Given this list of marker genes PROM1, RLBP1, AIPL1, AHI1, PDE6A, ARL6, FBLN5, CFHR3, CFAP418, IMPDH1, PRPF6, CERKL, ABCA4, CFH, MFRP, ZNF408, ZNF513, RPGR, BBS2, IFT172, NRL (NCBI Gene Id 4901), KIZ, ALMS1, PRPH2, DHDDS, PRPF8, CC2D2A, EYS, GUCA1B, GDF6, SPATA7, KLHL7, FAM161A, IFT88, TOPORS, CRB1, SEMA4A, IMPG1, IQCB1, TMEM98, RPE65, CRX, TUBB4B, PDE6B, LCA5, RP1, TUB, SAG, USP45, MERTK, CLRN1, EFEMP1, TTC8, CA4, CNGB1, PCARE (photoreceptor cilium actin regulator), PRPF31, RHO, PRCD, TULP1, POMGNT1, C1QTNF5, IFT140, RGR, PDE6G, OFD1, REEP6, RP2, KCNJ13, CNGA1, PRPF4, SNRNP200, GUCA1A, ARHGEF18, FSCN2, AHR, IMPG2, RD3, MAK, AGBL5, CTNNA1, DHX38, CFI, ROM1, SLC7A14, ESPN, LRAT, IDH3A, ARL3, UNC119, XYLT2, HMCN1, RP1L1, NEK2 (NIMA related kinase 2), NR2E3, USH2A, PCYT1A, CEP290, IDH3B, RBP3, BEST1, HGSNAT, KIAA1549, APOE, BBS1, CDHR1, RPGRIP1, SCAPER, XYLT1, GUCY2D, ABCC6, CFHR1, NMNAT1, RDH12 (retinol dehydrogenase 12), ARL2BP, PRPF3, RP9, here is a description of the gene set: Human Gene Set: HP_DRUSEN species: Homo sapiens Drusen Drusen (singular, 'druse') are tiny yellow or white accumulations of extracellular material (lipofuscin) that build up in Bruch's membrane of the eye.